Given this list of marker genes Hoxb13, Frs2, Esr1 (NCBI Gene Id 13982), Sfrp1, Hoxd13, Igf1, Fgfr2, here is a description of the gene set: Mouse Gene Set: GOBP_PROSTATE_GLANDULAR_ACINUS_MORPHOGENESIS studied in species Mus musculus The process in which the prostate glandular acini are generated and organized. The glandular acini are the saclike structures of the gland.